The following is a description of a gene set: Human Gene Set: GOBP_BIOLOGICAL_PHASE species: Homo sapiens A distinct period or stage in a biological process or cycle., and this is the list of marker genes: WNT5A, MSX2, TGFB2, FERMT1, SPINK5, WNT10B, GAL, CDH3, CTNNB1